The following is a description of a gene set: Genes predicted to be targets of miRBase v22 microRNA hsa-miR-367-5p in miRDB v6.0 with MirTarget v4 prediction scores > 80 (high confidence targets). studied in species Homo sapiens from publication Chen Y, Wang X (PMID 31504780) Human Gene Set: MIR367_5P, and this is the list of marker genes: IGF1R, ITK, CDC16, SALL1, RPS6KA5, AJUBA, HIPK3, CDH13, FBXO33, PTEN, ONECUT2, ADNP, YAF2, RUFY2, NRIP1, ABCE1, MCMDC2, PRKAA1, VRK3, MACROH2A1, RASSF5, MEIS2, GLCE, MDFIC, TMED2, OAS1, NSUN7, ALG9, CHIC2, PPP2CB, ZNF793, CNKSR2 (NCBI Gene Id 22866), SPATA18, SMARCA5, BBX, PLA2G4E, CNOT6, ZBED4, SLC6A4, ACADL, ZMAT2, MBNL2, XYLT2, PADI6, ACER3, MED26, LILRB2, SDK1, MARVELD3, MRI1, ZBTB20, ZNF131, RPS6KA3, BLZF1, SSPN, ERBIN, KDM6B, PLG, HNRNPH3, CARTPT, NR3C1, ZSCAN32, ZCCHC14, FGL2, SLC25A46, RBM20, CREB5, UBE2D3, CKS2, GLIS3, CASP7